The following is a description of a gene set: studied in species Homo sapiens An electrocardiographic anomaly in which the ST segment is observed to be located inferior to the isoelectric line. ST segment depression Human Gene Set: HP_ST_SEGMENT_DEPRESSION, and this is the list of marker genes: PRKAG2, CITED2, GATA4, NKX2-5, TLL1, GATA6, ACTC1, RYR1, TNNC1, MYH6, CLCNKB, SLC12A3, TBX20